Given this list of marker genes Smpd3, Nat8l, Slc22a3, Snca, Slc18a1, Actb, Mapk15, Slc29a4, Slc22a2, Rab3b, Prkn, Gdnf, Slc6a2, Tor1a, Slc22a1 (solute carrier family 22 (organic cation transporter), member 1), Park7, Slc6a3, Drd2, here is a description of the gene set: The directed movement of catecholamine into a cell. Mouse Gene Set: GOBP_CATECHOLAMINE_UPTAKE species: Mus musculus